The following is a description of a gene set: species: Homo sapiens Human Gene Set: GOMF_CALCIUM_ION_BINDING Binding to a calcium ion (Ca2+)., and this is the list of marker genes: EGFL6, ANKEF1, FAT1, UNC13B, C1S (NCBI Gene Id 716), NECAB1, CAPN11, PROZ, DGKB, FBN2, FER1L5, MYL4, PCDHA6, PCDH15, RAPGEF2, NAALADL1, CABYR, ANXA2, ALOX15B (arachidonate 15-lipoxygenase type B), MASP2, PCDHB3, REG4, CRACR2B, CETN1, S100A2, PCDHA13, ITGB1BP2, CALM2, MMRN1, EFCAB5, CUBN, NOTCH4, PCDHB7, SVEP1, CAPNS1, EFCAB12, SELENON, FAM20C, PCDH17, ITGA5, NOTCH2NLC, ESYT2, ACTN2, ATP2A1, CELSR3, SPOCK3, EFCAB6, VIL1, PCLO, PCP4, PON1, THBD, OTOL1 (otolin 1), RPTN (repetin), RHBDL3, SRR, CABP5, GLCE, CDH7, CALML6, S100A16, SMOC2, MAN1A1, C1R (NCBI Gene Id 791254), AIF1L, PCDHGA12, GAS6, FBLN7, ADGRL3, CBL, EFCAB10, TTYH1, NCALD, SNCA, ESYT1, PLS3 (NCBI Gene Id 5358), PCDHGC5, PCDH7, SCUBE2, NPNT, PPP2R3A, PITPNM1, TGM3, PLCD4, NELL1, ALPL, PCDH12, SLIT2, DLL3, ADGRE2, SPARCL1, LTBP3 (latent transforming growth factor beta binding protein 3), PCDH9, JAG1, ANXA7 (NCBI Gene Id 310), CLEC6A, ATP2B2, S100B, STAB1, CAPNS2, NCS1, EML1, CLSTN2, DCHS1, CABS1, MAN1C1, ADAMTS13, CD93, PCDHB14, EFCAB9, PCDHB11, ENPP3, PLA2G10, PCDHGC3, CDH3, EFCAB3, OC90, CABP7, EDEM2, PRRG4, SPARC, FLG (NCBI Gene Id 83406), PITPNM2, ATP2A2, GALNT3, CLGN, SCIN, NIN (ninein), PCDH8, EFHD2, DOC2B, BRAF, STIM2 (stromal interaction molecule 2), PLCH2, THBS3, SULF2, PCDHA1, DST, BMP1, ADGRV1, CASQ2, CDH13, PITPNM3, OCM2, NID1 (nidogen 1), CRNN (NCBI Gene Id 51413), CDHR2, COMP, PCDHB2, RHOT2, TNFAIP6, RCN1, S100Z, GUCA1A (guanylate cyclase activator 1A), UMOD, SLIT3, PPEF2, MATN3, CPS1, PADI3, REPS1, TTYH2, CPNE6, CSN2, CASQ1, FSTL4, CANX, NOTCH3, FKBP7, HMCN1, PCDH19, EFHC2, SYT10, NOL3, TBC1D8B, CAPN2, VSNL1, EFEMP2, ASPN, ATP2C1, CALB1 (NCBI Gene Id 793), CDH2, CALR, S100A7A, EHD1, PNLIPRP2, GUCA1C, EFCAB2, RASGRP1, PLCG1, GJB2, HSPG2, DGKG, S100A1, NID2, DYSF, TESC, MEGF8 (multiple EGF like domains 8), PCDHGA6, DSG2, ITSN2, CIB3, SYT7, S100A12, CD320, SELL, CDH22, EFCAB11, PRRG1, LALBA, SYT1, LRP4, PCDHB1, LTBP4, TUBB4A, TNNC2, MCTP1, FBN1, MYOF, PLA2G2D, FAT4, PLCB2, F9, CRB2, COLEC11, CLSTN3 (NCBI Gene Id 9746), SGCA, RPH3A, PADI2, FBLN5, RCN3, AMELX, MICU2, PLSCR3, PLCZ1, MACF1, GNPTAB, PKDREJ, ADGRE5, LPCAT1 (lysophosphatidylcholine acyltransferase 1), MMP12, HRNR, CRELD1, FAT2, NUCB2, WDR49, ADGRE3, PCDHB6, MYL2, HMCN2, PVALEF, CIB2, NOTCH1, GPD2, ADGRL4, DAG1, F10, CRTAC1, DLK1, NOTCH2NLA, CDH12, ASAH2, CGREF1, DNAH7, ANXA1, SCGN, ITPR3, PROS1, EGF, CCDC47, MAN1A2, TPO, MYL6B (myosin light chain 6B), DCHS2, CEMIP2, KCNIP3, CDHR3, ANXA4, S100A4, PCDHB15, VLDLR, IHH, PCDHA3, USP32, EFCC1, NINL, OTOF, CDH18, NELL2, CDH24, MEGF6, ITIH1, PLSCR1, MYL6, MICU1, RAB44 (RAB44, member RAS oncogene family), MCTP2, EDEM1, EFEMP1, PCDHGB1, TPM4, THBS2, PLCB1 (NCBI Gene Id 23236), DLL4 (delta like canonical Notch ligand 4), LRP2, CANT1, PCDHGB7, JAG2, EFCAB8, DSG3, TKT, CASR, PCDHGB5, STIM1, PCDHGA7, S100A5, MEX3B, CELSR1, PCDH11Y, CDH19, PCDHB12, F2, SMOC1, CDH23, PRSS2, S100A3, RGN, ACTN4, CDH4, MATN4, FSTL1, PDCD6, APCS, NOTCH2NLB, OCM, S100A14, AMY1C, PCDHB5, SNCB, EFHB, SRI, CABCOCO1, CDH17, EDIL3, BGLAP, NDUFAB1, PADI1, MYL11, RCVRN, CAPN8, ITPR2, PLCB3, PLSCR2, ANXA6, ANXA11, EEF2K, CRP, PLCH1, PLA2G2C, SYT4, MMP13, S100A13, SLC25A23, ANXA5, MYL5, S100A8, CLEC3B, DSPP, PLA2G5, CBLC, PKD1L2, REPS2, CDK5R1, UNC13A, SCUBE3, AOAH, HPCAL4, ADGRE1, RYR2, NBPF26, CABP2, PLA2G2F, CAPSL, NCAN, PAMR1, EFHC1 (NCBI Gene Id 94915), GUCA1ANB-GUCA1A (GUCA1ANB-GUCA1A readthrough), MYL7, PLA2G1B (NCBI Gene Id 5319), PPP3CA, DSG1, MAN1B1, PLA2G4F, PLCD1, PCDHGA1 (NCBI Gene Id 56114), SYT11, CIB1, DHH (desert hedgehog signaling molecule), PCDHGA11, PPEF1, CETN2, EGFL8, EYS (eyes shut homolog), CLEC4A, RHOT1, ASPH, TLL1, PLA2G4D, SLC25A12 (solute carrier family 25 member 12), PLA2G12B, ITSN1, TTYH3, S100A6, S100A7L2, CBLB, CRB1, PCDHB13 (NCBI Gene Id 91491), MYL12A, DSC1, CACNA1B, PCDHGA9, FKBP14, EGFLAM, ARSA, PCDHB8, CRELD2, PCDHGA4, CD248, PCDHA8, DNASE1L3, PCDHB18P, IQGAP1, PVALB, CAPN9, ANXA8 (annexin A8), TRPM2, DLK2, PCDHAC1, TCHH (NCBI Gene Id 7062), TNNC1, PRKCSH, CIB4, NRXN1, CLEC4E, F12, FBN3, SPOCK2, CDH10, PCDHA5, LRP8, TRPM5, PCDHGB2, PCDHB9, CELSR2, CCBE1, VWA2, HRC, PEF1, SPTA1, PCDHA4, RUNX1, CAPN3, ENPP1 (ectonucleotide pyrophosphatase/phosphodiesterase 1), TLL2, CDH15, TBC1D9, CALM3, DUOX2, CDH26, CPNE1, TPT1P8, F7, UMODL1, PCDHGA10, CAPS, CLSTN1, PLA2G4A, RASEF, AMY1B (NCBI Gene Id 277), ACTN3, PPP3R2, IDS, CDH1, ACTN1, AGRN, CDHR5, SWAP70, PCDHGB3, SLC25A13 (solute carrier family 25 member 13), MCFD2, EHD2, PRRG3, CRACR2A, NKD1, DSC3, CLXN, PLA2G12A, EGFL7, PCDHB16, DNASE1L2 (NCBI Gene Id 1775), MYL9, PPP2R3B, DNER, FKBP9, PCDHA7, EHD3, VCAN, SCUBE1, CALML4, SLC25A25, PLSCR4, CDH11, CALB2, GUCA1B, STAB2, S100P, EDEM3, MATN1, PCDH11X, GCA, CAPN12 (NCBI Gene Id 337935), CDHR4, KCNIP4, FSTL5 (follistatin like 5), CHP2, CALM1, SNTN (NCBI Gene Id 651293), BAIAP3, FKBP10, SUSD1, PCDHA10, CDH20, TGM2, LPCAT2, PPP3CB, S100A7, PCDH10, ZZEF1, PCDH18, NOTCH2 (NCBI Gene Id 55574), MYL12B, CDH5 (NCBI Gene Id 1003), CDH6, GRM7, ANXA13, EPS15, FSCB, TTN, ITPR1, BNIP2, KCNIP1, MYL10, AOC3, CAMKK2, PLA2G4B, MYL3, S100A9, GSN (gelsolin), PGS1, S100G, PLA2G4C, HABP2, HSPA5, OIT3, PCDHA2, ANXA8L1, PLA2G4E, SHH, S100A11, CHP1, RCN2, EFHD1, FAT3, CDH9, DGKA, PCDH20, NECAB2, PCDHB4, PRF1, MASP1, SLC8A1, SLC25A24, RASGRP4 (NCBI Gene Id 115727), CAPS2, CAPN14 (calpain 14), LCP1, CAPN1, S100A10, CETN3, CDH16, PCDH1, ESYT3, HPGDS, SDF4, PLA2G2E, SELP, ADAM8, MYL1, RASGRP3, HSP90B1, AOC1, LTBP1, RYR3, ENPP2, GRIN1, FBLN1, SPTAN1, TPT1, PLS1, AIF1, MGP, RASGRP2, FLG2, EPS15L1, PCDHAC2, TBC1D9B, PKD2, EHD4, HPCA, PROC, LOXL2, PPP3R1, PCDHGB4, EPDR1, LDLR, NECAB3, HEG1, VWCE, PCDHA11, TRPM4, AMY2A, MICU3, PCDHGA3, PCDHGA2, LPL, DSG4, TPD52, CDH8, SPATA21, FBLN2, CALML5, DMP1 (dentin matrix acidic phosphoprotein 1), UNC13C, ANXA3, CABP1, MELK, PADI4, PCDHA12, PRRG2, NKD2, SNED1, PCDHA9, MATN2, CALML3, ACER3, SYT5, DUOX1, LRP1, KCNIP2, LTBP2, PLCB4, PCDHGA5, NOX5, PKD2L2, RAB11FIP3, PCDHGB6, PKD2L1, PCDHGC4, ANXA2P2, CALN1, RET, DSC2, BCL2L10, CALR3, AMY1A, C2CD5, NUCB1, PADI6 (peptidyl arginine deiminase 6), SPOCK1, SULF1, HPCAL1, DLL1, CACNA1E, PNLIPRP1, CALU, RYR1, PCDHB10, ASTN2, P4HTM, THBS1, EFCAB7, CDHR1, ITGB1, EFCAB14, PRSS3, ANXA10, RAB11FIP4, THBS4 (thrombospondin 4), LRP1B, ITLN1, PCDHGA8, LETM1, PLA2G2A, PAM (NCBI Gene Id 5066), ANXA9, SLIT1, CABP4, TENM2 (teneurin transmembrane protein 2)